The following is a description of a gene set: species: Homo sapiens Human Gene Set: REACTOME_SLC15A4_TASL_DEPENDENT_IRF5_ACTIVATION SLC15A4:TASL-dependent IRF5 activation, and this is the list of marker genes: IKBKB, SLC15A4, IRF5, TASL, IKBKG, CHUK